The following is a description of a gene set: studied in species Mus musculus Mouse Gene Set: GOBP_LATERAL_SPROUTING_FROM_AN_EPITHELIUM The process in which a branch forms along the side of an epithelium., and this is the list of marker genes: Nog, Sulf1, Bmp7, Trp63, Fgfr2, Gli2, Shh, Wnt5a, Celsr1, Ar, Bmp4, Vangl2, Fgf10